The following is a description of a gene set: Any process that modulates the frequency, rate, or extent of B cell apoptotic process. studied in species Mus musculus Mouse Gene Set: GOBP_REGULATION_OF_B_CELL_APOPTOTIC_PROCESS, and this is the list of marker genes: Foxp1, Aurkb, Cd74, Mir20b, Mir25, Il10, Pten, Irs2, Mir92-1, Il2, Mir92-2, Mir363, Mif, Cd44, Myc, Noc2l, Cd24a, Il3, Fnip1, Mir106b, Mir93, Mir19b-2, Ada, Bax, Mir18b, Ormdl3, Slc39a10, Bcl2, Mir106a, Mir19b-1, Pdcd1, Hsh2d, Bcl10, Lyn, Bcl2a1a